The following is a description of a gene set: species: Homo sapiens Human Gene Set: GSE40068_CXCR5NEG_BCL6NEG_CD4_TCELL_VS_CXCR5POS_BCL6NEG_TFH_DN T follicular helper (Tfh) cells play a pivotal role in germinal center reactions, which requires Bcl6 transcription factor. To analyze their relationships with other effector T cell lineages and their stability in vivo, we developed and analyzed a new Bcl6 reporter mouse alone or together with other lineage reporter systems. Assisted with genome-wide transcriptome analysis, we show substantial plasticity of T cell differentiation in the early phase of immune response. At this stage, CXCR5 appears to be expressed in a Bcl6-independent manner. Once Bcl6 is highly expressed, Tfh cells can persist in vivo and some of them develop into memory cells. Together, our results indicate Bcl6 as a bona fide marker for Tfh polarized program. Genes down-regulated in CXCR5- BCL6- CD4+ T cells versus CXCR5+ BCL6- follicular helper T cells. from publication Liu X, Yan X, Zhong B, Nurieva RI, Wang A, Wang X, Martin-Orozco N, Wang Y, Chang SH, Esplugues E, Flavell RA, Tian Q, Dong C (PMID 22987803), and this is the list of marker genes: STAT4, POGLUT2, RAPH1, ATF6, CYSLTR2, IGSF8, PCTP, CERCAM, CDC25B, TMEM37, DHDH, SEMA4F, ABTB3, IL18RAP, RRAS (NCBI Gene Id 6237), PTPN13 (protein tyrosine phosphatase non-receptor type 13), PRKAR2A, FCGR2B, ARHGAP26, USP20, ZBTB42, SYTL3, CDC42EP3, PADI2, RECK, ACOT7, LGALS1, TRPS1, GLUD1, CRMP1, CD44, ADAM8, HIC1, GARS1, ATP8B4, ARHGAP18, CRIP1, S100A11, GALNT3, GALM, ROM1, DNASE1L1, SLC26A11, EHBP1L1, HSD11B1, RNF157, TBL2, MCOLN2, BAG3, POGK, MOGS, RMDN2, ITGB2, AFG3L2, RHOC, TPI1, TSPAN31 (tetraspanin 31), POU6F1, ANXA1, RAP1GAP2, MDFIC, SNAI3, DNAJC15, KLRC1, CTNNA1, ENDOD1 (NCBI Gene Id 23052), KIF5C, DKKL1, TPST2, ID2, OSTF1, PKP4, NDUFAF7, PTGER2, CCR5, GOLM1, RAB19, TRMT112, VIM, ZDHHC2 (NCBI Gene Id 51201), GPC1, PLEKHM3 (pleckstrin homology domain containing M3), USP48, GZMM, ST3GAL6, CST7, DBNDD2, GPR155, HIGD1C, CEP15 (NCBI Gene Id 57415), TXN, PILRB, ERRFI1 (ERBB receptor feedback inhibitor 1), ENTPD1, SLAMF7, RBM47, RAB23, PDE2A, NRARP, RORA, BAIAP3, KLRD1, CYB5R4, ITGB1, CXCR6, IFNGR1, EFHD2, TMT1A, GRAMD2B, GPRIN3, HOPX, CARHSP1, GSAP, ANXA2, LYST, WWP1, PVT1, CAPSL, ERN1, YBX3, SIDT1, NUCB1, CDH1, RCN1, SMAD3, SLC25A24, BCL2A1, PLSCR1, AHNAK, HID1, PTGER4, THTPA, YES1 (YES proto-oncogene 1, Src family tyrosine kinase), GARIN3, ST14, FHL2, STX11, LSS, SLC2A8, SLC25A53, PARP16, NQO2, SORL1, GBP4, IFI27, KCNK5, IL18R1, PLAC8, MAP2K3, CORO2A, CAPN2, MTHFS, CEMIP2, NFIL3, LAIR1, CHSY1, TMBIM1, APOBR, PTPN22, MICAL1, DYM, LAX1 (NCBI Gene Id 54900), B3GNT5, ABCA2, NIBAN1, PCGF2, APRT, RALGDS, NOD1, TAFA3, TMEM109, GNG2, ACSBG1, LYSMD2, APOBEC3B, SLC2A1, IL2RB, PPP3CC, NAT10, TTC39C, PRR13, NEK7, RBL2, AKR1B10, CTSW, B4GALNT4, EPSTI1, DOCK5, LDAF1, TNFRSF18, GAB3, IL12RB2, MAF, MNS1, TRAF1, PTPN4, HGSNAT, POGLUT3, FLOT1, LGALS3